Given this list of marker genes FAM169A (NCBI Gene Id 26049), COQ10B, COX8C (cytochrome c oxidase subunit 8C), BAD, TNMD, NDUFB2, ADAP2, RNASET2, KPNB1, DYNC2I2, SDHB, AIFM3, FAM162A, BPHL, ATP5MF, TMEM65, MCU, ITPR3, COX8A, CHCHD6, PARP1, SLC25A37, EBP, RNF185, SLC25A28, SFXN4, PPTC7, UQCRC2, NDUFA8, MTX3, MTOR, ABCB7, TNKS, DMAC2L, TOMM40, ENY2, CPNE1, TOR4A, CYP27A1, MRPS27, HCCS, SORD, TMEM147, FGR, DDX19B, PANK2, TMEM242, CYP2E1, UCP3, DCTN5, C11orf65, PLPP7, CD38, FIS1, OSBPL3, PHB2, ANXA11, MSTO1, DES, CFL1, CRLS1, MT-CO1, COX14, COX6C, CHCHD3 (NCBI Gene Id 54927), NUP214, HMGA1, MRPS14, TSPO2, PTPN1, CYB5R3, MICU3, NIPSNAP2, DAO, PLAAT3, IRGM, LYRM7, AGPAT5, MLXIP, UQCC5, TRMT10B, ATP5MJ, UBB, BLOC1S1, SERAC1, MRPS21, GLE1, CLGN, SMIM26, GATM, MRPL36, AIFM2, PTGER3, ARMCX2, WTAP, NLRP10, TOMM7, TMEM126B, RNF13, SLC25A25, HOXA7, MRPL2, MRPL23, NDUFA2, UGT2B28, ERBIN, MRPS17, SIRT5, CHMP1A, ACAD11, MOAP1, SLC25A4, SLC25A24, SUN3, FXR1, SLC44A1, IRAG2, COX16, SPATA19, CIBAR1, BCL2L1, L2HGDH, P2RX6 (NCBI Gene Id 9127), NRXN1, RPS6KB1, MTX2, ATP5PO, SLC25A53, FDXR, APEH, NELL1, TPR, COX7A1, COX19, SNUPN, RAB40B (NCBI Gene Id 10966), PLCB1 (phospholipase C beta 1), MRPL16, DUX4, NXT1, OXA1L, CYP27B1, CYP11A1, CEMIP, CALR, SREBF1, GK2, TMEM11, KPNA2, TIMM23, PCID2, MRPL28, OMA1, COQ3, TMEM14C, MRPL24, ITGB4 (NCBI Gene Id 3691), PGRMC1, SLC25A19 (NCBI Gene Id 60386), MAD2L1BP, NDUFB5, CETN2, DHX37, BCHE, LMNTD1, MRPL32, CDH5, RTN4IP1, SPIRE1, TREX1, COQ8A, NDUFC2, PCYT1A, UQCR11, GNAQ, FLVCR2, ATP5F1C, GRK5, NDUFA11, MARCHF5, AMBRA1, PTCD3, HPN (NCBI Gene Id 3249), SDCBP, VPS4A, ABL1, ZBTB1, PHB1, TMCO1, GABBR1, SMOX, CLIC1, DMPK (NCBI Gene Id 60405), NDUFS3, MRPS23, CCAR1, ATP5MG, CYC1, RPS3, MINDY3, GAPDH, SLC25A11, TMEM33, GATA6, MTMR8, THEM4, MRPL39, ADRA1B, RRM1, SLC16A3, STAU2, DELE1, LPIN1, COX10, NUTF2, CABS1, TRIM14, TRAK1, INTS5, SLC22A18, ADCK1, OGT, NUP54, NUP62, HMOX1, ACSL3, TSPO, PHF11, UNC50, TIMM50, MTLN, DCTN1, CHDH, PMAIP1, BROX, NDUFB1, ABCB10, ERN1, SORL1, SLC30A2, BLTP1, ALOX5, DNAJB12, SLC25A40, POMZP3, RGPD6, SLC25A21, SLC22A4, SRC, LMO7, CD2AP, MRPL44, RANBP17, TMPO, SPG7, MTARC2, GPD2, FOXRED1, MT3, IMMP2L, LEMD2, GDAP1, NDUFB6, MT-ATP6, ASS1, RGPD8, ATP1B4, MPC1, SULT1E1, NDUFAB1, SLC25A16, RNF144B, DISP3, NUP160, NUP35, PLPP6, C12orf43, COA8, SLC52A3, UQCC6, SLMAP, BID, LRRK2, TOMM22, UQCC3, MT-ND3, CHCHD4, BAK1, PLN, COQ6, TMEM160, CNR1, PCNA, CENPF, NDUFS5, LDHB, SLC8B1, BNIP3L, LYPLA1, MRPS35, MTMR6, DNAJB2, ACKR2, ABCD1, KRAS, MRPL22, ATAD1, IPO9, COA4, ATP5PB, MRPL20, COA5 (cytochrome c oxidase assembly factor 5, NCBI Gene Id 493753), NDUFB4, FPGS, ACSL6 (acyl-CoA synthetase long chain family member 6), SIGMAR1, ZBED1, UQCC1, TOR1AIP2, AFG3L2, COA7, COX5B, SPNS1, BRI3BP, SPAST, BCL2, ATP5MC2, C19orf12, SFXN5, GRPEL2, PTGDS, PTRH2, RNF123, MTG1, TOR1AIP1, SPDYA, STX1A, NRP1, MRPL1, NUP58, BCL2L2, ANXA4, NXT2, FAM210B, FANCL, RAB32, BANF1, MRPS34, CYP24A1, RARS2, MRS2, CLPB, IMMT, SLC25A46, NSMF, CETN3, CHMP7, DNAJC15, TIGAR, RTEL1, COX6B2, KCNK9, RRP12, POM121, NDUFC2-KCTD14, IFFO1, TRAF3IP3, GUF1 (GTP binding elongation factor GUF1), TMEM53, RCC1L, MX1, SLC25A47, ACOT9, CDC25C, DUSP18, CHMP2A, ATAD3B, MIEF1, NDUFA7, ACSL4, MRPS10, GCHFR, HLCS, PARP6, ECSIT, CISD2, SLC25A34, DNAJC2, COX17, SLC30A9, KCNH1, BCL2A1, PDSS1, YME1L1, MRPS18B, SLC39A9, GADD45GIP1, KGD4, NUP188, TOMM6, RAP1GAP2, NDUFS2, ATG9A, TMEM97, TMEM120A, STARD13, PRNP (NCBI Gene Id 96713), TENT4A, OSBPL6, COX7B, H2BW1, MGST1, COQ2, KPNA1, AFG1L, CARD19, TIMM44, SFXN3, THOP1, ATPSCKMT, TRAP1, TUFM, COX6B1, ATP5PD, CYBB, SARM1, PIGBOS1, MNS1, NXF1, UFL1, ALDH18A1, NDUFAF1, HSD17B8, CCDC90B, MRPL49, NEMP1, SLC25A41, SYNE2, MFF, MFSD10, MRPL51, GCAT, TMX1, HKDC1, DTX2, PINK1, MRPL46, EGFR, MPC1L, NUP37, COQ4, MYOC, MTARC1, TNPO3, RETSAT, MT-CYB, DNAJC1, CASP8, RPS27A, CYP2U1, RNF220, MTHFD2L, MRPS12, NDUFA5, SLC25A26, AAAS (NCBI Gene Id 8086), TIMM29, GRK2, NDUFB3, NUP107, MAPK3, USP30, MAPK8IP1, CEP89, PCM1, LMNTD2, MRGPRF, MRPS5, TOMM34, KIF5B, COQ9, TMEM18, MRPS25, NUP43, NAT8L, IPO11, LMNB2, PPOX, OPA1, UBE2I, TMEM126A (transmembrane protein 126A), PAM16, TMEM168, MRPS7, TMEM176B, PPP2R2B, CHCHD2, BLTP2, AK2, AKAP6, ARL2, TOR1B, TIMM23B, MRPL55, PARL, SLC25A6, MRPS15, PTGS2, NDUFA10, ATR, HIGD1A, ANGEL1, IL15RA, MRPL57, NME4, MRPL58, TCHP, CKMT1A, NUP88, HABP4, CHMP4B, BCL2L11, AIFM1, SLC22A3, BOK, EMD, HTRA2, RGPD1, MRPL45 (mitochondrial ribosomal protein L45), MRPL43, CASC3, TYMS, AKIRIN1, RAB5IF, VDAC2, SLC25A30, UQCC2, GRPEL1, MRPL37, WDR3, SENP2, HSP90B2P, KLHDC2, PPP1R15A, PRKCA, MPV17, NDUFAF6, LETM2, QRICH2, CPS1, ATP5ME, IMMP1L, COQ5, FLVCR1, SQOR, ATP11B, TMX4, TAFAZZIN, MUL1, ENSG00000293600, SURF1, EI24, SNN, MRPS18C, MPC2, PDSS2, PPP1CC, ROMO1, UQCRC1, SPHK2, NME6, BICD2, NDC1, COX5A, HAX1, ERAL1, SEPTIN4, HACD3, MRPL48, CHMP6, NBR1, NARF, TIMM17A, HADHA, ZNF383, SMPD4, SLC25A35, MT-CO3, MRPL9, PLA2G4A, ATP5F1E, HK1, UBA52, BNIP2, TYRO3, PRKG2, IPO5, MTERF3, ENDOG, ULK1, COASY (NCBI Gene Id 80347), RDH13, MRPS31, ZFTRAF1, MGST3 (NCBI Gene Id 9272), MRPL27, POLA1, ITSN1, NDUFS6, DHCR7, SLC25A13, ARL6IP6, CNEP1R1, SLC25A29, TBC1D20, STAT3, ATP5F1A (ATP synthase F1 subunit alpha), IPO7, VAMP1, SLC25A12, RNF180, IGF2R, OGDH, SLC25A31 (solute carrier family 25 member 31), PLD6, SFXN2, MFN1, ALPL, SORT1, SOD1, SHISA5, SPART, MAPKAP1, ALOX5AP, TDH, FECH, CBX3, NLRP6, NDUFA4, PSEN1 (NCBI Gene Id 5663), FOXO3, BBC3, NPIPB3, TIMM8A, MTG2, NME3, PDE4D, UBXN4, CHCHD7, TMEM186, PARP11, CDS2, ZNF354C, TRABD, GFER, MCL1, IFI27L1, CHCHD1, ABCF1, NDUFS4, CHMP4C, SPATA46, ATRAID, TMEM14A, CEBPZOS, FAM156A, UCP1, SIRT1, KASH5, NOA1, ABCB8, TXLNG, GHRHR, KPNA4 (NCBI Gene Id 84857), KIF28P, MRPS28, TIMM22, SMAD1, NDUFV3, AGPAT4, BECN1, PISD, SLC25A42 (solute carrier family 25 member 42), IFI6, MT-ATP8, PRODH, FATE1, PTGES, NDUFB7, MTCO2P12, MTDH, ACSL5, CIDEA, CCNI, TIMM9, MTCH1 (NCBI Gene Id 51627), CHMP2B, PTPMT1, CPT1B, CTDNEP1, SLC25A5, EPHA3, TOR3A, DHRS2, CASK, RTCB, MRPL12, CSE1L, MRPL17, EXOG, XPO1, NDUFA6, COX20, INTS2, COQ8B, BMF, ARMCX1, SCO2, MRPL15, NEMP2, MRPS9, PRODH2, RHOD, COA1, MATR3, AGFG1 (ArfGAP with FG repeats 1), TMC6, LYN, MT-ND1, CYP11B2, CHMP1B, ATP5F1B, BNIP1, ACADL, BCL2L13, MRPL42, UQCRFS1, CUEDC2, CYB5A, LMNB1, SYNE4, NAPEPLD, QTRT2, SCAI, OSBPL8, KLK6, DPY19L2, COX7B2, COX6A2, BIK, SPIN1, LBR, MIX23, PLEC, OIT3, MRPS24, NOC4L, YEATS4, RIF1 (replication timing regulatory factor 1), ZDHHC8, MRPL21, TMEM209, AQP8, ATP5F1D, DMAC1, GHDC, PRICKLE1, GCH1, SLC25A20, UQCRQ, MRPL35, CLMN, TMEM177, NUP62CL, DUSP2, TOMM20, HK2 (NCBI Gene Id 3099), MPV17L2, SLC9B2, PRKN, FAM156B, RHOT1, ADRA1A, NEU4, PGRMC2, SLC25A15, CDK2, GK, UCP2, PARK7, ATP5F1EP2, CHMP5, ABCB6, PLA2G4C, PRELID1, TAF3, APOO, SRSF1, NDUFA12, SPATA18, FUNDC1, NDUFA3, PNPT1, MAJIN, CYP1A1, UBIAD1, GSDMD, NRGN, TIMM17B, SLC25A18, PLA2G4B, SYNE1, ARL2BP, DNM1L, AKT1, THG1L, NUP85, NDUFS8, RANBP1, VDAC3, MRPL33, POM121L2, ROGDI, SLC30A1, CENPV, MRPL30, PRICKLE2, RGPD2, GUCY2D, NUP153, ZC3HC1, NDUFAF2, ELK1, TMEM135, ARMCX6, EPHA4, VRK2, UQCR10, STARD7, ITPR1, SUN5, NDUFB9, CHMP4BP1, COX4I1, PRELID3A, MRPL18, ARMC1, PGS1, MAP1LC3B, DIABLO, PLEKHN1, NDUFS7, SLC25A32, SLC22A14, SPAG4, MYOF, ATP2A3, CC2D1B, PMPCA, NNT, DTL, MRPL38, NR4A1, MT-CO2, APP, FAM209B, WASF1, UQCRHL, ETFDH, BRIP1, ACACB, MVP, FBXW11, LRPPRC, DST, CIAPIN1, CANX, MCM3AP, HSPD1, GOLPH3, TM7SF2, MYO19, HTATIP2, SUV39H1, LEMD3, CCND2, S100A6, TRIM27, SLC25A45, RB1CC1, MTA1, MRPL10, MPL, PSEN2, CHCHD10, VAT1, ENO1, SLC25A43, CPT2, MRPL3, QTRT1, NDUFS1, GTPBP4, MRPS11, GNAZ, ATP5PF, NUP210L, PIK3C2B, CYB5B, MRPS22, HADHB, FKBP8, SURF4, C9orf72, BNIP3, DUSP21, CLPX, MYORG, FKBP10, MRPL11, MLX, TRIAP1, MRPS26, XPO4, UQCRB (NCBI Gene Id 7381), TMEM14DP, SLC8A3, SLC44A2, STING1, PPIF, CHMP4A, MT-ND4L (NCBI Gene Id 4539), CKMT1B, NDUFAF4, DNAJB14, SEPHS1, RAB11FIP5, DNAJC19, WDFY3, SLC25A36, NDUFB8, TMEM170A, COX18, ITPRIP, ATP5MC3, COX4I2, MCUB, RGPD4, DCAKD, SYNE3, MTCH2, COX6A1, ATPAF1, SLC25A39, COA6, UQCRH, TMEM109, ANTKMT, PAK1 (NCBI Gene Id 5058), COX7A2P2, IFT122 (NCBI Gene Id 55764), MICU2, MTFP1, AK9, MRPL47, SLC25A10, LETMD1, SLC25A27, TAMM41, MAVS, GPAM, EXD2 (NCBI Gene Id 55218), MIGA2, AGPAT3, NDUFA1, MT-ND5, SMAD3, NPC1, MAD2L1, COQ7, FBXL4, SLC11A2, PEMT, IPO8, MRPS33, AURKAIP1, ZNFX1, GHITM, TWNK, PLRG1, SMIM20 (NCBI Gene Id 389203), SMIM30, SLC25A3, SCO1, ACADVL, GTF3C3, SUOX, NDUFV1, MISFA, SLC27A3, RAN, RANGAP1, SLC25A1, RBMX2, QSOX2, NDUFA9, SOX10, COX11 (cytochrome c oxidase copper chaperone COX11), TMEM38A, MRPL14, POM121B, CEP128 (centrosomal protein 128), VDAC1, MICOS10, MFN2, MRPL54, SDHA, MT-ND2, RGPD3, ARMC12, GABRB1, YWHAE, SIRT4, MRPL19, MIEF2, IST1, SLC25A22, SELENON, SMDT1, NDUFAF5, NDUFV2, NRM, NGRN, OTC, NUP205, TTC19, DNAJC30, EIF6, FZD9, TMEM14EP, HSD3B1, COA3, EFHD1, NDUFB11, CDK4, MRPL53, FZR1, MRPS6, NUP42, SNCA, PLSCR3, TERB2, CEPT1, MCUR1, LGALS3, PUM2, BDH1 (3-hydroxybutyrate dehydrogenase 1), TMEM201, RMDN3, MIGA1, RANBP2, TMX2, CRAT, RSAD2, NLN, VPS13A, COX7C, HINT2, MRPS2, RAE1 (ribonucleic acid export 1), TMEM14B, SLC25A51, GUCY2F, INSR, MYO6, SUMO1, NPIPA1, BCS1L, MRPL34, NLRX1, PARP8, TRPC7, DAP3, MGARP, AQP1, RTN4, RBM15 (RNA binding motif protein 15), MT-ND6, ANKRD17, ALAS1, SDHC, PML, PRELID2, NDUFAF3, COX15, RAB29, ARMCX3, CALR3, NUP210, MRPS30, ALAS2, NDUFB10, TUBB, MAOA, DNAJC11, TOMM20L, EIF5A, CISD1, REXO2, PARP16, MRPS16, OSBPL7, MICU1, RHBDD1, MRPS18A, PAK5, GPAT2, STMP1, VPS13C, TMEM43, CALM3 (calmodulin 3), SLC25A52, PGR, NOS1AP, RHOT2, INPP4A, SH3BGRL2, IFI27, ATF2, FAM209A, PRR14, NUP98, TNKS2, SLC25A33, SLC25A23, COX7A2, SYNJ2BP, REPIN1, SLC25A38, SLC29A3, CHCHD5, MT-ND4, TERB1, HIGD2A, TTC12, SEC13, RNF6, TMEM70, ATCAY, PLAAT1, FUNDC2, SLC25A48, MGST2, CYCS, MAIP1, CHMP3, COX7A2L, ATXN3, GOLT1A, MLIP, ZMPSTE24, ACAD9, NUCB2, MRPL41, TOR1A, MX2, NUP50, MACO1, ARMC10, ACADM, PHF20, PGAM5, TIMM21, HSPA9, CKMT2, MRPL13, DARS2, GUCA1B, CCND1, NDUFA13, RNF5, DNASE1, TEX2, SLC5A1, UTP18, TMC8, LETM1, RGPD5, TIMM10, VAPA, TRAPPC2B, ZNF224, LRRC59, POM121C, STAR, IKBKE, MAD1L1, MTNAP1, TMEM38B, CPOX, NAV3, SDHAF3, XPO7, STOML2, TOR2A, NUP155, CREB3L4, TOMM70, ATAD3A (ATPase family AAA domain containing 3A), GPX4 (glutathione peroxidase 4), SDHD, NUP93, KPNA3, MRPL4, FAF1, CACYBP, CMTM3, KMO, DPY19L2P2, PRKCZ, LDHD, BCL2L10, VPS4B, BAX, FAM111B, APOOL, PRELID3B, SCGB1A1, IFI27L2, NPAP1, MTX1, MRPL52, SFXN1, UQCC4, TMEM120B, NUP133, CBX5, MTFR1L, OTULINL, LMNA, CCDC51, ABCG2, TMCO5A, RNF43, RAC2, MAOB, TNRC18, ATF6, REEP1, CYP11B1, CMC4, TOMM40L, CPTP, TIMM8B, ACSL1, SLC25A2, SAMM50, AMBP, SLC25A44, HSD3B2, STX1B, AHCTF1, ATP5MGL, DEGS1, RAB7A, SMCP, RAF1, PNPLA8, SH3GLB1, EDNRB, TMEM223, PI4KB, PDE2A, GRAMD4, XPOT, SUN2, GPER1, BRAP, UBC, ATPAF2, AGK, MICOS13, PET100, SHMT2, PHF8, PLA2G2A, DHODH, CLCA2, AEN, ATP5MC1, POLR2M, RBM15B, CLU, SUN1, SENP1, TRA2B, SEH1L (SEH1 like nucleoporin), LTC4S, SLC25A14, AKAP1, DHFR2, TIMMDC1, KCNK16, MRPL50, THAP7, CPT1A, MRPL40, SLC41A3, ABHD6, COQ10A, ATP5MK, TIMM13, PAFAH1B1, NDUFC1, TIMM10B, EPC1, INTS1, SCRN1, NUDT9, TOMM5, CYP27C1, here is a description of the gene set: species: Homo sapiens A double membrane structure enclosing an organelle, including two lipid bilayers and the region between them. In some cases, an organelle envelope may have more than two membranes. Human Gene Set: GOCC_ORGANELLE_ENVELOPE